Given this list of marker genes MAGEA8, MAGEA9, ZNF141, SERPINA4, DGCR5, IFNA10, THPO (NCBI Gene Id 84434), NPFF, KRT34, SMYD3, CCN6, CDH8, DOCK3, CLCN3, IFNA14, SPATA2, CTRL, NHEJ1 (NCBI Gene Id 79840), ERCC4, PTPN20, CDH4, SLC4A4, LGI1, GPR171, MPP3, SLC17A3, POU6F2, FGF18, PCDHGB7, TTTY1, MYH2, FAS, TMEM26, ST8SIA1, PRKCA, PART1, STAC, OR10H3 (olfactory receptor family 10 subfamily H member 3), PRPS1L1, SLC46A3, FOSL1, LORICRIN, CAMTA1, COL19A1, MPZL1, CYP2C19, IPO9, FBXL4, IL11RA (interleukin 11 receptor subunit alpha), POLR1HASP, ATP10B, ARL3, GNG4, SULT4A1, ATP2B2, RYR1, KCNA5, FAM13A, WBP4, GUCY2F, CALN1, DAZL, DDX52, ABCB1, GCM1, DNAJC22, GCA, OR2B6 (olfactory receptor family 2 subfamily B member 6), PGM3, B4GALT6, NEDD4L, ADGRL2, MINDY2, HCRTR2, FGF2, CTSB, PDE4D, ROR2 (receptor tyrosine kinase like orphan receptor 2), BRINP3, EYA1 (EYA transcriptional coactivator and phosphatase 1), ABCB10, GPR19, MLLT10, MDM2, ZNF157, S100A5, RGS7, DRD1, ZNF132, DBT, PTPRB, HTR1E, ATXN3, RYR3, COL14A1, VSTM4, TPD52L1, APOBEC1, TBXT, CA3, ZNF202, PLPPR4, NEB, TTN, AQP7, HEPH, MON2, TLL1, UBE4B, ADRB1, RB1CC1, GLRA3, ZNF266, ZSCAN26, ADAM20, NFAT5, KRT2, RSC1A1, FSHR, SLC4A8, SLC17A1, PVR, GUCY2C, NTNG2, NR3C2, ICOS, IL7, MAP3K1, CFH, PHF10 (NCBI Gene Id 55274), POU6F1, DMPK, CCR3, TANC2 (NCBI Gene Id 80259), CCL16, SPA17, RBMXL1, IFNA2, IGKV7-3, SIX6, RREB1, PHLDB1, TRIM24, MAP2K7, GYS2, HNF1A, TSSK2, R3HCC1L, BMP10, ABO, PSD, HSPA1L, LRP4, LIPC, ISL1, CHRNB4, LILRA1, TNK1, IFNA1, GABRB2, CDC73, PPM1E, ITGBL1, SLC15A1, BRD4 (bromodomain containing 4), PCM1, ERC2-IT1, P2RY10, HSD3B2 (hydroxy-delta-5-steroid dehydrogenase, 3 beta- and steroid delta-isomerase 2), FGA, IL4, JADE3, CEP162, BIRC5, TENM4, RNF24, TBX19, RORB, MAP2, COL8A1, CDR1, COQ7, CXCL5, FUT1 (NCBI Gene Id 2523), EPHB2, PDE6A, H3C6, GJB5, NR1I2, ATF2, ADAMTSL3, LECT2, CPEB3, IFNA8, MC5R, IL5, PAX6, CMKLR2, SPRR2C, ITIH3, GHRHR, MYT1, KPNA1, LILRA4, CAMK4, SRPK3, GYPA, AOC4P (amine oxidase copper containing 4, pseudogene), PCDHB17P, CRHR1, CADM4, CACNA2D1 (calcium voltage-gated channel auxiliary subunit alpha2delta 1), RXRG, OCM, CD8A, FLRT2, EXOC4, ATP8B1, SLC33A1, JRKL, F2RL1, LINC03124, ZBTB14 (zinc finger and BTB domain containing 14), IL16, SGCD, PHOX2B, LDB3, KLRC4, SIM2, NOS2, KLHL23, DRC3, EHHADH, GPR18, ATP4B, PTPRR, SLC6A2, PSG1, ABCC8, ZBTB40, CPB2, LPAR4, FAM110B, GRIK1, NPAS2, AMMECR1 (AMMECR nuclear protein 1), EDIL3, DMD, RPS6KA5, NOL4, ATF6B, AKAP3, COLGALT2, CYP2E1, SLC26A4, FZD5, IFNW1 (interferon omega 1), RBMS3, SUPT3H, RAD51D, here is a description of the gene set: studied in species Homo sapiens Neighborhood of MAGEA8 Neighborhood of MAGEA8 melanoma antigen family A, 8 in the MORF expression compendium Human Gene Set: MORF_MAGEA8